The following is a description of a gene set: Any process that stops, prevents or reduces the frequency, rate or extent of potassium ion export across the plasma membrane. Human Gene Set: GOBP_NEGATIVE_REGULATION_OF_POTASSIUM_ION_EXPORT_ACROSS_PLASMA_MEMBRANE studied in species Homo sapiens, and this is the list of marker genes: KCNH2, NEDD4L, KCNE3, KCNE5, NEDD4, WWP2